The following is a description of a gene set: from publication Chen Y, Wang X (PMID 31504780) studied in species Mus musculus Genes predicted to be targets of miRBase v22 microRNA mmu_miR_7119_5p in miRDB v6.0 with MirTarget v4 prediction scores > 80 (high confidence targets). Mouse Gene Set: MIR_7119_5P, and this is the list of marker genes: Snapin, Tbc1d30, Shisa9, Smco1, Stum, Pef1, Ppard, Pknox2, Glmp, Fam163b, Nectin1, Dpp6, Zfp637, Usp50, Irx5, Csnk1g1, Gzmb, Rps6kc1, Dhdh, Nt5dc1, Bloc1s5, Slc18a1, Sox6, Isl1, Slc6a17, Zdhhc15, Lhfpl1, Alkbh1, Scg2, Kmt2a, Fgfr4, Tomm34, Mymk, Zfhx2, Sncb, Tmem63a, Pde1b, Cyp2u1, Mink1, Srgap3, Nek8, Klf13 (NCBI Gene Id 80528), Ube3a, Cdhr1 (cadherin-related family member 1), Ctnnd1, Alx4, Zfp36l2, Atg7, Mex3a, Ppp1r9b, Actb, Smap1, Bin1, Tbc1d7, Col1a1, Lyz3, Tceanc2, Lrrc58, Wfdc6a, Cbx6, Tbc1d23 (NCBI Gene Id 98049), Atf7, Gng11, Zfp646, Tdrd3, Ube2f, Nfix, Map3k13, Lhx6, Abca5, Mrpl50, Frmd7, Ccdc68, Ptk2b, Nfasc, Lama3, Slc22a27, Wfdc6b, Clns1a, Dlk1